The following is a description of a gene set: Free fatty acids regulate insulin secretion studied in species Mus musculus Mouse Gene Set: REACTOME_FREE_FATTY_ACIDS_REGULATE_INSULIN_SECRETION, and this is the list of marker genes: Gna15, Gna11, Plcb2, Cd36, Ffar1, Gnaq, Plcb1, Acsl4, Acsl3, Plcb3, Gna14